Given this list of marker genes GAPDH, CD9, PLBD1, PHB2, SLC2A3, TPI1, here is a description of the gene set: from publication Korkola JE, Houldsworth J, Chadalavada RS, Olshen AB, Dobrzynski D, Reuter VE, Bosl GJ, Chaganti RS (PMID 16424014) species: Homo sapiens Human Gene Set: KORKOLA_CHORIOCARCINOMA_UP Adult male germ cell tumors (GCTs) comprise distinct groups: seminomas and nonseminomas, which include pluripotent embryonal carcinomas as well as other histologic subtypes exhibiting various stages of differentiation. Almost all GCTs show 12p gain, but the target genes have not been clearly defined. To identify 12p target genes, we examined Affymetrix (Santa Clara, CA) U133A+B microarray ( approximately 83% coverage of 12p genes) expression profiles of 17 seminomas, 84 nonseminoma GCTs, and 5 normal testis samples. Seventy-three genes on 12p were significantly overexpressed, including GLUT3 and REA (overexpressed in all GCTs) and CCND2 and FLJ22028 (overexpressed in all GCTs, except choriocarcinomas). We characterized a 200-kb gene cluster at 12p13.31 that exhibited coordinated overexpression in embryonal carcinomas and seminomas, which included the known stem cell genes NANOG, STELLA, and GDF3 and two previously uncharacterized genes. A search for other coordinately regulated genomic clusters of stem cell genes did not reveal any genomic regions similar to that at 12p13.31. Comparison of embryonal carcinoma with seminomas revealed relative overexpression of several stem cell-associated genes in embryonal carcinoma, including several core stemness genes (EBAF, TDGF1, and SOX2) and several downstream targets of WNT, NODAL, and FGF signaling (FGF4, NODAL, and ZFP42). Our results indicate that 12p gain is a functionally relevant change leading to activation of proliferation and reestablishment/maintenance of stem cell function through activation of key stem cell genes. Furthermore, the differential expression of core stem cell genes may explain the differences in pluripotency between embryonal carcinomas and seminomas. Genes from the 12p region that were up-regulated in choriocarcinoma cells compared to normal testis.